The following is a description of a gene set: species: Mus musculus Binding to a major histocompatibility complex molecule; a set of molecules displayed on cell surfaces that are responsible for lymphocyte recognition and antigen presentation. Mouse Gene Set: GOMF_MHC_PROTEIN_BINDING, and this is the list of marker genes: H2-Q10, Klrk1, H2-D1 (NCBI Gene Id 547343), H2-M11, H2-M10.2, H2-M2, Cd81, Klra17 (killer cell lectin-like receptor, subfamily A, member 17), Cyrib, Vcp, Mfsd6, H2-T10, H2-T23, H2-M10.4, H2-M10.6 (histocompatibility 2, M region locus 10.6), Cd8b1, H2-T3, Pilrb1, H2-Q6, Marchf1, Pilra, Kir3dl2, Cd74, H2-Q4, Tubb5, H2-T22 (histocompatibility 2, T region locus 22), Fcrl6, Pdia3, H2-M1, H2-M10.1, H2-Q2, Lag3, Tap2, Marchf8, Atp5f1b, Cd4, H2-M9 (histocompatibility 2, M region locus 9), Atp5f1a, H2-K1, Kir3dl1, H2-Q1, Bcap31, Pirb, H2-M5, Col2a1, Derl1, H2-M10.5, Cd244a (NCBI Gene Id 55952), H2-M10.3, H2-Q7, Pilrb2, Klrd1, Tap1